Given this list of marker genes Trp53, here is a description of the gene set: This event has been computationally inferred from an event that has been demonstrated in another species.<p>The inference is based on the homology mapping from PANTHER. Briefly, reactions for which all involved PhysicalEntities (in input, output and catalyst) have a mapped orthologue/paralogue (for complexes at least 75% of components must have a mapping) are inferred to the other species. studied in species Mus musculus part of: Regulation of TP53 Expression and Degradation Reactome Pathway: Regulation of TP53 Expression electronically inferred by orthology from the curated human pathway